Given this list of marker genes LAMA5, ACAN, HAPLN1, TNC, NCAN, BCAN, HAPLN4, HAPLN2, TNR, HAPLN3, PTPRZ1, VCAN, here is a description of the gene set: The extracellular matrix of the perisynaptic space (the extracellular space adjacent to the synapse) and the synaptic cleft. species: Homo sapiens Human Gene Set: GOCC_SYNAPSE_ASSOCIATED_EXTRACELLULAR_MATRIX